The following is a description of a gene set: Genes down-regulated in comparison of peripheral blood mononuclear cells (PBMC) from healthy donors versus PBMCs from patients with type 1 diabetes at the time of diagnosis. Human Gene Set: GSE9006_HEALTHY_VS_TYPE_1_DIABETES_PBMC_AT_DX_DN Objective: We hypothesized that type 1 diabetes (T1D) is accompanied by changes in gene expression in peripheral blood mononuclear cells (PBMCs) due to dysregulation of adaptive and innate immunity, counterregulatory responses to immune dysregulation, insulin deficiency and hyperglycemia. Research Design and Methods: Microarray analysis was performed on PBMCs from 43 patients with newly diagnosed T1D, 12 patients with newly diagnosed type 2 diabetes (T2D) and 24 healthy controls. One and four month follow-up samples were obtained from 20 of the T1D patients. Results: Microarray analysis identified genes differing in expression between newlydiagnosed T1D patients and controls at a false discovery rate of 0.05. Changes in expression of interleukin-1β (IL1B), early growth response gene 3 (EGR3), and prostaglandin-endoperoxide synthase 2 (PTGS2) resolved within four months of insulin therapy and were also observed in T2D suggesting that they resulted from hyperglycemia. With use of a knowledge base, 81/genes could be placed within a network of interrelated genes with predicted functions including apoptosis and cell proliferation. IL1B and the MYC oncogene were the most highly-connected genes in the network. IL1B was highly overexpressed in both T1D and T2D, whereas MYC was dysregulated only in T1D. Conclusion: T1D and T2D likely share a final common pathway for beta cell dysfunction that includes secretion of interleukin-1β and prostaglandins by immune effector cells, exacerbating existing beta cell dysfunction, and causing further hyperglycemia. The results identify several targets for disease-modifying therapy of diabetes and potential biomarkers for monitoring treatment efficacy. from publication Kaizer EC, Glaser CL, Chaussabel D, Banchereau J, Pascual V, White PC (PMID 17595242) species: Homo sapiens, and this is the list of marker genes: HCAR3, CORO1A, GUSBP11 (GUSB pseudogene 11), F2RL1, ADGRG3, BHLHE41, SPATA2L, S100P, TBC1D9, VNN3P, FRAT2, CDH17, CRYBB2, HLA-DRB4, EGR1, BICDL1, TRAF3, NUTF2, DBR1, DHX32, EREG, TNFAIP6, POLR1G, EGR3, STAG3L4, CHTOP, ADO, WDR3, BLM, BASP1, FPR2, IQCE, MANSC1, ELF1, NRBF2, MAGEA6, IL1R2, TNFRSF10C, UBAP1, OLFM4, ADGRE3, EGLN1, OSTF1, TMEM185B, MAFB, PDK4, USP20, WIPI2 (NCBI Gene Id 51623), PNP, S100A8, DNAAF5, CDK9, FFAR2, CDK14, CCNB2, HEPH (hephaestin), CXCL8, SELL, SLPI, DNAJC11, CCR7, FOSB, FOSL1, SOCS3, ARHGDIG, ADAM19, S1PR1, EHD1, PDCL, MGAM, SERPINB2, IL1B, RGS2, MAP3K20, BTG2, IGLV3-19, MCL1, PARM1, SLC19A1, NAMPT, SVIL, SLC25A20, SOHLH2, RCL1, G0S2, CCL2, MZB1, IGKC, INPP5D, HBB, MEFV, PADI2 (NCBI Gene Id 11240), MAU2, CISH, CXCR1, KIAA0040, CCR1, PCBP4 (NCBI Gene Id 57060), THRAP3, PIK3CB, GAR1, LCMT2, MYC, HLX, AQP9, CCRL2, TREML2, ALPL, PIM1, CPT1A, MCM3, ASPM, TLR1, CSNK1D, RRAGA, CR2, ZNF155, CELSR1, BSCL2, PI3, THBD, RGCC, MRAS, ST14, CWC25, CXCL2, ZNF654, MKLN1, CXCR2, PTPRE, DUSP6, NDEL1, TLR6, CHM, IER2, CXCL1, AKTIP, AURKA, CDC20, IRF4, ABCA1, EGR2, ZFTA, TREM1, PTGS2, GIGYF2, IGLJ3, SPAG8, PDCD6, IGF2R, LMTK2, PTPN21, MCRS1, COCH, ACKR4, KRT23, PPP1R10, SGK1, PYCR3, EZH2, CCNA2, KIAA0319, CYP4F3, LIMK2, IGLL3P, CCDC106, ACSL1, MYNN, LDB1, ZNF133, IVNS1ABP, FOLR3, OSBPL2, KCNJ15, NFYA, PSG2, FAM30A, COL9A3, ZFP30, STEAP4, ST8SIA4, SEMA4D, CEACAM4, BTN2A1, LIG1, SNX19, NCF4, LAMB4, IGLV1-44, CKAP2 (cytoskeleton associated protein 2), ZFP36, ELL2, NCAPG, C3AR1, NAP1L2, MME, ZHX2, TRIB1